The following is a description of a gene set: from publication Chen Y, Wang X (PMID 31504780) studied in species Mus musculus Mouse Gene Set: MIR_1899 Genes predicted to be targets of miRBase v22 microRNA mmu_miR_1899 in miRDB v6.0 with MirTarget v4 prediction scores > 80 (high confidence targets)., and this is the list of marker genes: Rtl3, Ccdc126, Ldlrap1, Hoxd10, Tatdn3